The following is a description of a gene set: Peroneal muscle weakness studied in species Homo sapiens Weakness of the peroneal muscles. Human Gene Set: HP_PERONEAL_MUSCLE_WEAKNESS, and this is the list of marker genes: REEP1, SARDH, PMP22, LMNA, FKTN, TRPV4, GDAP1, GYG1